Given this list of marker genes SCARB1 (NCBI Gene Id 949), IFI16, BGN, KYNU, ARHGDIB, PRMT5, FAM53B, RASA3, MPP1, IGF2R, CNP, BTG1, DDOST, TRAM1, SORL1, TNFAIP3, MCM2, AMD1, CD83, ALOX5, ACTR1B, IL2RG, CAPRIN1, GNB1, ARPC1B (NCBI Gene Id 10095), CD53, VAMP7, ALDH18A1, RGS19, PTPN6, FABP5, DEK, TFRC, PBXIP1, SGK1, CDKN3, TRIM22, EIF5, PSG11, LMO2, CLN3, IL4R, HCLS1, UBE2I, PTGES3, DUSP6, PTPRC, IFIT3, RANBP1, HMGN4, SLA, TMED2, JAK1, RGS1, UBE2D3, NUTF2, UCP2, NFKBIA, ITGAL, DPH1, CUL4A, NR3C1, AIF1, VHL, LBR, HMGB2, GDI2, OAS1, HNRNPA0, SSR1, HLA-DMB (NCBI Gene Id 3109), CD48, UBE2S, GLRX, TYK2 (NCBI Gene Id 7297), FKBP5, CSNK2A1, NMI, ISG20, ST3GAL1, H2AX, PLCG2, RHOB, BST2, SUSD6, CD52, CRIP1, DNMT1, MX2, NEU1, GYPC, EDEM1, NNT, ARPC4, LCP1 (NCBI Gene Id 3936), TOP2A, PTPN7, HLA-DQA1, NFKB1, CDC20, CBX3, here is a description of the gene set: studied in species Homo sapiens Genes in the cancer module 177. Human Gene Set: MODULE_177